The following is a description of a gene set: The directed, sodium-independent, movement of organic anions into, out of or within a cell, or between cells, by means of some agent such as a transporter or pore. species: Mus musculus Mouse Gene Set: GOBP_SODIUM_INDEPENDENT_ORGANIC_ANION_TRANSPORT, and this is the list of marker genes: Slco2a1, Slco1a1, Slco1a8 (NCBI Gene Id 632662), Slco1a5, Slco4a1, Slco4c1 (NCBI Gene Id 227394), Slco1c1 (solute carrier organic anion transporter family, member 1c1), Slc22a6, Slco5a1, Slco1a7, Slco1a6, Slco1b2, Slco3a1, Mfsd10, Slco2b1, Slco1a4, Slco6c1, Slco6d1